The following is a description of a gene set: species: Homo sapiens Human Gene Set: SA_PROGRAMMED_CELL_DEATH Programmed cell death, or apoptosis, eliminates damaged or unneeded cells., and this is the list of marker genes: BID, BAK1 (NCBI Gene Id 578), CASP8AP2 (NCBI Gene Id 9994), BCL2L1, BCL2, BAD, BAX (NCBI Gene Id 581), APAF1, BCL2L11, CASP9, BCL10, CES1